Given this list of marker genes SPRR1B, SMIM5, PLSCR2, ABHD5, GPR87, VGLL1, PAX9, RAB11FIP1, PPL, ADGRF4, MIEF2, TMPRSS11E, SERPINB2, KRT19, KRT17, HOPX, ENSG00000268833, IL36RN, PRSS22, THAP1, IL1RN, MT1H, KRT4, TRIP10, BMS1P20, IL1R1-AS1, MAL, YBX3, MUC21, FUT6, C15orf62, MOSPD1, TMPRSS11B, SPINK5, S100A9, MT1E, MT1X, ETNK2, RDH13, CNFN, MT1G, KCNG1, CLIC3, ITFG2-AS1, LINC00958, MT2A, PRSS27, CEACAM7, ATP10B, GABRP, C6orf132 (NCBI Gene Id 652183, chromosome 6 open reading frame 132), CYSRT1, SDCBP2, FAM83A, TMEM54, SERPINB5, LGALS3, DSG2-AS1, NCCRP1, FAM3D, CDKN2B, LDAF1, RNF39, EIF1, TMEM80, SCEL, PTK6, IL1RL2, MAP3K9-DT, KRT16, TTC9, PHLDB3, EREG, PTGES, AHNAK2, CERS3, CRISP3, FOXE1, RNF141, S100A2, A2ML1, C15orf48, ZNF554, ADGRF1, KRT78, TMPRSS11A, FABP3, TTC22, LYPD3 (NCBI Gene Id 94931), CDKN1A, SSH3, HEBP2, OAS2, GID8, POF1B, ZNF750, DKK2, H19, NIBAN2, PKP1, GRHL1, RNF222, APOBEC3B, MAP1LC3B, TRMO, LYPD2, FTH1, CAPN14, MAB21L4, SIM2, TTC9-DT, MUC20, GRHL3, KRT80, METRNL, PI4K2A (phosphatidylinositol 4-kinase type 2 alpha), PERP, NAPRT, RLIG1, FLG, SLC25A23, AMN, EPHX3, CEACAM5, SFN, ATP6V0A4, NR1D1, SGTA, KRT15, MARCO, CXCL17, GCNT3, NECTIN4, PHLDA3, CSTA, TMEM79, WFDC21P, PITX1, DUOXA1, SERINC2, FUT3, DOCK9-DT, F3, APOBEC3A, RRAGC, FOXQ1, KRT14, MUC22, RRAGD, LINC00393, VSIG2, PAX1, CEACAM6, KLC3, PLEKHN1, YPEL3, TMPRSS11D, KLHL21, HES4, NUDT19-DT, GJB2 (NCBI Gene Id 2706), TP53INP2, TINCR, SPRR2D, LCN2, SH2D4A, SPRR3 (NCBI Gene Id 6707), IER5, SAMD9, B3GALT5-AS1, OSGIN1, BNIPL, RNF223, CRCT1 (NCBI Gene Id 54544), ECM1, SPRR2A, ETHE1, NDRG2, CYP2W1, BEST1, XDH, IGF2, CTSV, CNGA1, OVOL1, KRT13, GLTP, ZNF555, RHCG, AVPI1, PPDPF, ZNF365, GIRGL, B3GNT3, B3GALT5, PPP1R13L, IVL, TACSTD2, FUT2, RAB9A, TMC1, CBR3-AS1, ZNF812P, DSC2, MUC4, B3GNT8, PADI1, here is a description of the gene set: Marker genes curated from the annotated cluster as represented in the Descartes Human Gene Expression During Development database. from publication Cao J, O'Day DR, Pliner HA, Kingsley PD, Deng M, Daza RM, Zager MA, Aldinger KA, Blecher-Gonen R, Zhang F, Spielmann M, Palis J, Doherty D, Steemers FJ, Glass IA, Trapnell C, Shendure J (PMID 33184181) species: Homo sapiens The gene expression program underlying the specification of human cell types is of fundamental interest. The study authors generated human cell atlases of gene expression and chromatin accessibility in fetal tissues. For gene expression, the study authors applied three-level combinatorial indexing to >110 samples representing 15 organs, ultimately profiling ~4 million single cells. The study authors leveraged the literature and other atlases to identify and annotate hundreds of cell types and subtypes, both within and across tissues. Our analyses focused on organ-specific specializations of broadly distributed cell types (such as blood, endothelial, and epithelial), sites of fetal erythropoiesis (which notably included the adrenal gland), and integration with mouse developmental atlases (such as conserved specification of blood cells). These data represent a rich resource for the exploration of in vivo human gene expression in diverse tissues and cell types. Human Gene Set: DESCARTES_FETAL_LUNG_SQUAMOUS_EPITHELIAL_CELLS